Given this list of marker genes COL1A1, TTF1, HOXA1 (NCBI Gene Id 3198), LRRC1, IFT81, AIRIM, ZNF767P, FKBP14, YWHAB, SF3A3, OSBPL7, DOCK2, YIPF2, ALDH7A1, PAK1IP1, SAP30L-AS1, MLLT11, IFT20, CTAGE1, SLFN12, PRRC2B, CPA2, MTRF1L, GAA, DCUN1D1, USP1, ITGB1BP1, COPS5, PIGA, NID2, SLC16A3, FBXO22, PTTG1, DNAJB4, PARP2, NOP56, COPS6 (COP9 signalosome subunit 6), CETN1, ADRM1, CDC42SE1 (NCBI Gene Id 56882), PDZD2, CCNB1IP1, HEBP2, PDE7B, HSP90AA1, CCNG1, ZFR, SEC24D, PYY, KCNG1, DCAF8, GRK6, THRAP3, GAS2L1, RTL8A, ATP6V0E2, SH3BGR, DNAJC10, NUP50, CDKAL1, MNAT1, KLHL12, CCN2, ABCC9, PPP2CA, ZNF749, PROP1, UBE3B, DHX16, YARS1, ABHD4, DHX29, INHBC, TRIAP1, ANK1, TACC3, ARHGAP35, SNRNP200, AMN, OSGIN2, RAP2A, TOP3A, EPAS1 (endothelial PAS domain protein 1), MTCH1, FHL2, NDUFC1, TXNRD2, CCDC181, NPRL2, RPL23AP32, CBX3, UCP2 (uncoupling protein 2, NCBI Gene Id 7351), TCF7L1, TRAPPC11, ZNF133, TAF1D, MGST3, PDE5A, AGA, FANCE, DHX57 (DExH-box helicase 57), RPN2, RPS17P5, ZNF135, MACIR, TOP6BL (TOP6B like initiator of meiotic double strand breaks), MKI67, CAMTA1, SLC22A11, ATAD5, LDHAL6B, NME6, LARP1, RAC3, SLC25A21, FTSJ1, CETN3, FLNB (NCBI Gene Id 8413), EXOG, ZKSCAN7, PFDN4, SNAP25, UBE3C, LRRTM2, SMIM10L1 (small integral membrane protein 10 like 1), FUCA1, PIK3C3, RBBP6, ARHGAP17, SERPINI2, HEATR6, PTPRH, XRCC1, CLDN4, AGPAT2, ANK3, DENND6B, ACADSB, CEACAM1, ERCC6, SLC30A9, PAIP2B, SIRT2, IKBKB, MTMR7, HSPA1L (heat shock protein family A (Hsp70) member 1 like), DNAH7, MUC16, CD19, GRIA1, CIAO2B, MUS81, FSHR, ARFIP2, MAST2 (NCBI Gene Id 23139), GCA, DCAF10, SRCAP, CCT7, BUB1, PEX5, TCL6, H2BC4, KRT1, S1PR4, EHBP1L1, PKIG, SLC6A12, ELP5 (NCBI Gene Id 23587), ZMYM5, SMUG1, POLD4, FUBP3, RINT1, MCC, SLC25A30, ADAMDEC1, ZNF408, TAF7, SAP30L, AVP, SEC31B, SMAD5, STN1, LSM5, HECTD3, CDC16, HEXA, NCBP2, ENTPD1, RGS3 (NCBI Gene Id 5998), ZNF204P, ADSS2, RTF2, RPL23AP53, TRAM2, here is a description of the gene set: Genes down-regulated in comparison of B cells from influenza vaccinee pre-vaccination versus those at day 7 post-vaccination. studied in species Homo sapiens Human Gene Set: GSE29618_PRE_VS_DAY7_FLU_VACCINE_BCELL_DN Systems vaccinology has emerged as an interdisciplinary field that combines systems wide measurements and network and predictive modeling applied to vaccinology. Here we used the systems vaccinology approach to study the molecular mechanisms underlying th from publication Nakaya HI, Wrammert J, Lee EK, Racioppi L, Marie-Kunze S, Haining WN, Means AR, Kasturi SP, Khan N, Li GM, McCausland M, Kanchan V, Kokko KE, Li S, Elbein R, Mehta AK, Aderem A, Subbarao K, Ahmed R, Pulendran B (PMID 21743478)